Given this list of marker genes NXT1, NAA35, NSMCE2, TRARG1, ST8SIA2, ASB1, SH2D5, KRCC1 (NCBI Gene Id 51315), KIFBP, GDI1, RASAL3, TATDN2, PAX7, CHST11, ABCC5, EP300, GID8, NDUFA13, ATG16L2, PLEKHN1, ACTR10, CAAP1, UBR1, APBB2, CDK5R1, USP34, SNRNP25, ARL15, CHAF1B, SLC37A3, TMEM63A, MIB2, STIM2, CEP20, MT4, CACNG3, VASP, SETD1B, RSPH3, USP33, SOX8, TTI1, FGD1, HOMEZ, ATP6V1G1, AP3B1, INTS11, MMS22L, FIG4, CIMIP1, NMB (NCBI Gene Id 4828), NNT, UBE4A, COTL1, RBM38, KBTBD2, EMC2, ADAM8, FBXO30, ATP5ME, B4GALNT4, CEP76, CFDP1, P2RX1, RALBP1, DDX20, CWC27, TBC1D31, CASKIN1, MXD3, SPACA9, CCL13, DPY19L4, TMEM209, CRISP2, DAP, AKTIP, MARCHF6, FCER1G, SCRN2, ZBTB9, LRRC46 (leucine rich repeat containing 46), RNF40, STC2, EXOSC4, CCDC88C, COPA, FSTL3, DYRK1A, MRPL19, HPS6, PIBF1, GABPB1, SEPTIN6, MARK2, LRRC58, CCDC63, HCST, ACTG2, GSTCD, PPHLN1, EFCAB2, CNGA4, C1QTNF7, CELF3, TWF2, METTL6, WDR5B, BAZ1B, PDCD10, MDM2, DEF8, MBD2, ADPRH, TRAPPC2B, MARS1, OR2T33, ATXN7L2, NTSR2, CDK6, ALDH3A1, NUP210L, RAB39B, SEPTIN14, NHERF2, PRODH, ACAD8, FKRP, WDR53, PDLIM7, LSM3, PAGR1, MTERF4 (NCBI Gene Id 130916), EME1, FRRS1, ART5, PRKCI, SPG11, PIP5K1B, HMGXB4, PRR9, AP2M1, DAB2, DMRTC1B, CARHSP1, PPWD1, VIM, CGGBP1, LCP1, SUV39H2, EBP, TXNDC12, ARB2A, NFAM1, ART3, ALDOAP2, RIDA, GK, SVIL, MRPS16, ACOX2, CYFIP1, SLC25A11, ATP11C, RER1, CLINT1, DNAAF9, GAL3ST4, ASGR1, TMEM52, CCP110, PLEKHA2, MAP3K20 (NCBI Gene Id 51784), PARP6, SIRT2, MGST1, SNRPC, S100A6, NMNAT2, PIGN, PIP4P2, GALC, ZNF296, BANF1, LONRF3, RETREG2, NOTUM, MRPL51, DOCK5, RHOG, ARSB, NRG3, TTC13, PAFAH1B2, COG6, RGS14, DYNLT3, UBR7, TIMM17B, EIF4G2, here is a description of the gene set: Type I and type II interferons (IFNs) bind to different cell surface receptors but activate overlapping signal transduction pathways. We examined the effects of a type I IFN (IFN-acon1) and a type II iFN (IFN-g1b) on gene experession in A549 cells and demonstrate that there is a common set of genes modulated by both IFNs as well as a set of gene specifically regulated by each, reflecting the activation of different signaling pathways. In particualr, IFN-g induced many more genes of the signaling pathways, apoptosis, and cytokine interactions than did IFN-a. Even with genes induced by both IFNs there were distinctive quantitativive differences in expression. IFN-g1b plays a major role in the induction and regulation of the complement pathway. Previous work has shown a synergistic antivral and antiproliferative effect of type I and type II IFNs in cell culture and in the treament of tumors in mice. We demonstrate that a majority of genes showed and additive effect of IFN-acon1 and IFN-g1b, but a subset of gene is synergistically induced; these incluce ISG10, MX2, OAS2, and other genes known to be involved in the antiviral response, TRAIL (TNFSF10) and caspases involved in apoptosis and chemokine genes RANTES, CXCL10, and CXCL11. Greater than additive transcription of some of these genes in the presence of both IFNs was confirmed by real-time kinetic RT-PCR. Elevated induction of many of these genes may be sufficient to explain the synergistic antiviral and antitumor effects of this combination of IFNS in vivo. species: Homo sapiens Genes up-regulated in epithelial cells (6h): IFNG versus IFNG and interferon alpha. from publication Sanda C, Weitzel P, Tsukahara T, Schaley J, Edenberg HJ, Stephens MA, McClintick JN, Blatt LM, Li L, Brodsky L, Taylor MW (PMID 16800785) Human Gene Set: GSE5542_IFNG_VS_IFNA_AND_IFNG_TREATED_EPITHELIAL_CELLS_6H_UP